The following is a description of a gene set: Complete lack of development of speech and language abilities. studied in species Homo sapiens Human Gene Set: HP_ABSENT_SPEECH Absent speech, and this is the list of marker genes: SYNGAP1, CHKA, EXOSC3, IARS1, HNRNPK, CAMK2B, COG8, VPS33A, FTH1, RAB3GAP2, PACS1, SUPT16H, PLCH1, YME1L1, STXBP1, CLP1, ATP10A, PSMB1, KDM5A, FGF13, CCND2, TUBB2A, SIK1, TTC5, COG4, SLC33A1, HSD17B10, POMT2, RPL10, INTS1, CSNK2A1, LMNB1, CHMP1A, USP7, ALDH18A1, TBL1XR1 (NCBI Gene Id 81612), AP3B2, HUWE1, PRUNE1, FKTN, GCDH, BCAS3, TRPM3, DOCK7, TRIO, FRMD4A, EP300 (NCBI Gene Id 2033), CRBN, NEXMIF, MINPP1, OFD1, GRIN1, CASZ1, RAB18, TRAPPC11, SMARCC2, EIF2AK2, RHOBTB2, PLP1, KIF5C, SMC1A, CNTNAP2, NCAPD2, AGTPBP1, NEDD4L, SYT1, TIMM50, SLC38A3, ELP2, MAST1, FOXH1, CLCN4, BMP4, DEGS1, GNAI1, ATN1, C2CD3, TMCO1, KCNAB2, ZIC2, PIGF, GFM2, PCGF2, GRIA2, KCNB1, LIPT2, SMARCA2, SMARCE1, PURA, MFSD2A, NSRP1, GMPPB, UFSP2, CAMK2A, ISCA2, HNRNPH1, KIAA0586, UGP2, OCA2, ATP1A2, OTUD6B, SLC12A2, PUS3 (pseudouridine synthase 3), CACNA2D1, RAC1, MAB21L1, SPTBN1, PSMC1, SMARCA4, CTNNA2, GABRD, WARS2, EIF4A2, SLC12A6, HTT, SLC13A5, DPH5, DALRD3, WDR37, PIGG, PPP2R1A, AIMP2, LAS1L, SLC1A4, GNAO1, CRIPTO, OPHN1, TRPV6, MBOAT7, DNM1L, SATB1, NGLY1, KCNT1, ATP6V0C, UFC1, EBP, CASK, CACNA1E, IFIH1, NSD1, ABHD16A, SPTSSA, PGAP3, GRIA1, TMEM147, TMEM106B, UBA5, GRIN2B, CDON, MRPS34, NTRK2, GABBR2, TNPO2, VARS1, ATP9A, SLC6A3, TBCD, SLC9A6, SCN3A (NCBI Gene Id 6328), SLC6A17, PI4K2A, AFG2A, ARID1A, GEMIN4, TMEM231, SNX14, CARS2, POLR3K, BLTP1, KCNH1, HCN1, TOR1A, GAS1, SZT2, PPP2R5D, ASH1L, DPAGT1, KCNQ5, RNU4-2, CLTC, GLI2, DOCK3, FRMPD4, MACF1, CPLX1, FGF8, KARS1 (NCBI Gene Id 3735), PPFIBP1, PIGV, TRIM8, ZBTB18, MPDU1 (NCBI Gene Id 9526), MAGEL2, ADSL, UBE3B, TCTN2, KLHL15, TANGO2, PLK4, EEF1A2, CREBBP, NCAPG2, FOXG1, MECP2, PPIL1, WDR45B, SUOX, MEF2C, ASXL3, CYFIP2 (cytoplasmic FMR1 interacting protein 2), ATP5F1A, FARS2, KAT6A, GPT2, ACBD6, HSPG2 (heparan sulfate proteoglycan 2), TRAPPC10, KCTD7 (potassium channel tetramerization domain containing 7), GRIK2, PTCH1, IQSEC1, EIF3F, TAF2, GRM1, GSX2, LINGO1, SOD1, PARS2, TCF4, DPF2, DOHH, VPS11, NR2F1, DPYSL5, GOT2, FRA10AC1, EHMT1, HIVEP2, MMP23B, PMPCB, ARID2, WARS1, WDR45, HID1, TELO2, EXOSC5, USP27X, HEPACAM, DISP1, CUL4B, RMND1, SLC39A14, ZSWIM6, WDR26, DPM2, DYRK1A, SCN1A, GNS, VPS41, IQSEC2 (NCBI Gene Id 4382), ARID1B, CLIC2, DLL1, WBP4, NTNG2, RERE, SHQ1, HIKESHI, EARS2, DOLK, UBE2A, DPYD, FKRP, KCNA2, TRIT1, CCDC47, MED12, MDH2, HNRNPC, UQCRQ, GAMT, SHH, NACC1, CACNA1B (NCBI Gene Id 774), PIGW, TKT, TOGARAM1, ST3GAL5, SLC4A10, KIF15, TFE3, PGAP2, MED23, DCPS, TBCK, ACTL6B, NFIX, AIMP1, YY1, SOX11, SRCAP, ZEB2 (NCBI Gene Id 9839), GNB5, STRADA, SMS, SATB2, RALA, UNC80, CENPJ, RAB5IF, GRIN2D, CNKSR2, AMPD2, VPS4A, GRIA4, LARGE1, ARFGEF1, TBCE, PIGA, SLC25A12, SMARCD1, BCL11B, KCNC2, SKI, SPEN, AHDC1, FGFR1, TREX1, PLAA, KCNJ10, SNRPN, PGAP1, MSL3 (MSL complex subunit 3), TRRAP, ARL13B, SETBP1, PRDM16, CHAMP1, RAB11B (RAB11B, member RAS oncogene family), DEAF1, DAG1, EXTL3, CACNA1I, GABRG2, POMT1, MKS1, MCOLN1 (NCBI Gene Id 57192), DARS2, CLPB, ADARB1, LMAN2L, SLC35B2 (NCBI Gene Id 347734), DHX30, GET4, HERC1, TOE1, RALGAPA1, HNRNPH2, SLITRK2, LNPK, SIX3, WDR4, DYM, SERAC1, TBC1D20, DNM1, TMTC3, MED25 (NCBI Gene Id 81857), COG3, ASPA, SPTBN4, POT1, KMT5B, PDPN, STAG2, SRPK3, MFF, CSPP1, FRRS1L, RNU7-1, POLR1A, TRAPPC6B, UBTF, PPP3CA, INTS8, GABRB2, HNRNPU, POLRMT, SHROOM4, ATP6V1A, ATG7, ALG14, UBE4B, H4C11, ODC1, TGIF1, PIGN, LINS1, SMARCB1, SLC1A2, PIGP, ZC4H2, PRKCZ, FOXRED1, ACOX1, PIGS, ALG11, LUZP1, STIL, KIF1A, TRAPPC2L, POGZ, CLCN3, ADNP (NCBI Gene Id 256440), SLC2A1 (NCBI Gene Id 6513), CDC42, MRPL12, FGF12, SOX4, HECW2, TUBA8, CACNA2D2, IRF2BPL, COPB1, WAC (NCBI Gene Id 55468), CNNM2, SLC35A2, PNPT1, PRPS1, UBE3A, UFM1, BRAT1, AP1S2, RARS2, CCDC88A, NODAL, NSUN2, ERLIN2, IREB2, NALCN, HDAC4, PYCR2, DENND5A